Given this list of marker genes Reep1, Rtp3, Rtp1, Rtp4, Rtp2, here is a description of the gene set: Mouse Gene Set: GOMF_OLFACTORY_RECEPTOR_BINDING Binding to an olfactory receptor. species: Mus musculus